Given this list of marker genes OTX1, LRCH2 (leucine rich repeats and calponin homology domain containing 2), UQCR10, LINC03042, TOP3A, HOXB6, TMEM51-AS1, EGR3, TBPL1, HSD11B1, PRIM1, TRMT10B, CLC, C19orf44, JARID2, CCDC25, SNAPC3, GRWD1, MEPCE, RPL7, MAX, IGF2BP3, PPP2R3A, VPS45, PA2G4, MRPL50, FOXP3, SPEF1, TMEM245, TBC1D8B, DCAF17, NFIB, CLASP1, EXO1, PNKD, STAU1, L3MBTL2, FGFR1, EHBP1, TMEM115, PROSER3, PRL, AAMP, LARS1, IMPDH2, METTL26 (NCBI Gene Id 84326), ZCWPW1, TRMT10A, UCKL1, ZNF189, IKZF3, SLC38A7, ZFHX4, BRD8, PRDM1, SOX5, NFIL3, TNPO2, RDH10, EPHB3, SSBP3, GABRB2, SMCR8, AKIRIN2, HSCB, LIX1L, ALCAM, CALR3, NDRG2, RABAC1, SHMT2, METTL8, PPOX, ESPL1, NUFIP2, ACP6, BTBD3, HMBOX1, CA11, LMO1, TNFRSF19, SH3BGRL2, MNT, AMMECR1, ELAVL2, OTP, AFF3, TMEM160, SNX1, FGF14, PBXIP1, HSPB6, RPS6KA5, ANGEL1, FAM227B, ATL3, RAD51B, ABR, SRSF6, DACH1, QTRT2, MLLT6, LMAN2, SREK1, MANEAL, THOC6, SIX4, HAS2, ZDHHC14, VCPIP1, BCKDK, CUTA, LIN7B (lin-7 homolog B, crumbs cell polarity complex component), NFATC3, INVS, CYSLTR1, TRPC4, RCN3, DOCK4, ADGRL2, BBX, ST3GAL2, RBFOX1, PCDH17, ZNF277 (zinc finger protein 277), CCDC191, R3HDM1, RDH14, ETV1, DQX1, KATNAL1, BUB1B, CDK9, INTS9, HOXC5, RAB5C, JADE1, FOXP2, SH2D6, BMPR2, HCFC1R1, MRPL24, PLAG1, DMD, DTWD1 (NCBI Gene Id 56986), TMEM51, here is a description of the gene set: Comprehensive identification of all functional elements encoded in the human genome is a fundamental need in biomedical research. Here, we present a comparative analysis of the human, mouse, rat and dog genomes to create a systematic catalogue of common regulatory motifs in promoters and 3' untranslated regions (3' UTRs). The promoter analysis yields 174 candidate motifs, including most previously known transcription-factor binding sites and 105 new motifs. The 3'-UTR analysis yields 106 motifs likely to be involved in post-transcriptional regulation. Nearly one-half are associated with microRNAs (miRNAs), leading to the discovery of many new miRNA genes and their likely target genes. Our results suggest that previous estimates of the number of human miRNA genes were low, and that miRNAs regulate at least 20% of human genes. The overall results provide a systematic view of gene regulation in the human, which will be refined as additional mammalian genomes become available. Human Gene Set: AACWWCAANK_UNKNOWN Genes having at least one occurrence of the highly conserved motif M108 AACWWCAANK in the regions spanning 4 kb centered on their transcription starting sites. The motif does not match any known transcription factor binding site. from publication Xie X, Lu J, Kulbokas EJ, Golub TR, Mootha V, Lindblad-Toh K, Lander ES, Kellis M (PMID 15735639) species: Homo sapiens